Given this list of marker genes Pomc, Srd5a1, Hsd3b9, Hsd17b3, Hsd3b5, Hsd3b4, Hsd3b2, Srd5a2, Cyp17a1, Cga, Hsd3b8, here is a description of the gene set: This event has been computationally inferred from an event that has been demonstrated in another species.<p>The inference is based on the homology mapping from PANTHER. Briefly, reactions for which all involved PhysicalEntities (in input, output and catalyst) have a mapped orthologue/paralogue (for complexes at least 75% of components must have a mapping) are inferred to the other species. electronically inferred by orthology from the curated human pathway part of: Metabolism of steroid hormones studied in species Mus musculus Reactome Pathway: Androgen biosynthesis